Given this list of marker genes UBE2D1, GABARAP, STXBP2, COTL1, LILRA2, TREM1, APOBEC3A, TYROBP, CTSS, RGS2, CCR1, SLC7A7, IGSF6 (NCBI Gene Id 10261), MS4A6A, DPYD, LILRB3, CLEC4A, CMTM6, DPEP2, EVI2A, SECTM1, SPI1, C5AR1, RHOG, TMEM127, NCF2, HCK, AIF1, ADA2, CD302, VNN1, TNFSF10 (TNF superfamily member 10), TLR2, TLR8, PYCARD, THEMIS2 (NCBI Gene Id 9473), CPVL, CD14, LILRA3, CD1D, NOD2, LILRA5, NAGK, STX11, LILRA6, LY96, ARRB2, CYBB, SULT1A1, SDCBP, TYMP, BST1, HK3, LILRA1, PILRA, IFNGR1, FCN1, ZNF467, EVI2B, TNFAIP2, HSD17B11 (hydroxysteroid 17-beta dehydrogenase 11), FRAT1, TBXAS1, S100A4, ITGB2 (NCBI Gene Id 3689), PSAP, S100A9, PECAM1, CFP, CASP1, ITGAX, TNFRSF1B, LILRB1, MYO1F, FGL2, PPT1, MNDA, CDA, GMIP, FCGR2A, FBXL5 (F-box and leucine rich repeat protein 5), CD93, SH3BGRL3, AP1S2, FCER1G, LILRB2 (leukocyte immunoglobulin like receptor B2), PLBD1 (phospholipase B domain containing 1), MCL1, RNF130 (NCBI Gene Id 55819), CLEC7A, LST1, CHST15, FPR1, FGR, here is a description of the gene set: Neighborhood of HCK Neighborhood of HCK hemopoietic cell kinase in the GNF2 expression compendium Human Gene Set: GNF2_HCK species: Homo sapiens